Given this list of marker genes Rrp8, Smpd3, Stk11, Phgdh, Trp53, Ecrg4, Rnf112, Capn3, Cyp27b1, Cdk5r1, Strada, Zbtb17, Rpl23, Gata6, Ezh2, Wdr6, Zfp503, Mybbp1a, here is a description of the gene set: A cell cycle arrest process that results in arrest during G1 phase, whereupon the cell enters a specialized resting state known as G0 or quiescence. Mouse Gene Set: GOBP_G1_TO_G0_TRANSITION species: Mus musculus